The following is a description of a gene set: Mouse Gene Set: GOBP_MATURATION_OF_LSU_RRNA_FROM_TRICISTRONIC_RRNA_TRANSCRIPT_SSU_RRNA_5_8S_RRNA_LSU_RRNA Any process involved in the maturation of a precursor Large SubUnit (LSU) ribosomal RNA (rRNA) molecule into a mature LSU-rRNA molecule from the pre-rRNA molecule originally produced as a tricistronic rRNA transcript that contains the Small Subunit (SSU) rRNA, 5.8S rRNA, and Large Subunit (LSU) in that order from 5' to 3' along the primary transcript. studied in species Mus musculus, and this is the list of marker genes: Ppan, Ftsj3, Wdr12, Pes1, Znhit6, Bop1, Urb1, Rpl7, Npm1, Rpl35, Ddx18, Rbm34, Gtpbp4, Pak1ip1, Znhit3, Nol9, Rpf2, Rpl7l1